Given this list of marker genes BROX, DNAAF10, GLCE, RAB11FIP2, FAM53C, KRTAP4-1, ZNF91, GRK2, NFAT5, PNRC1, NUAK2 (NUAK family kinase 2), ADA2, BHLHE22, FGD6, SCG3, DPY19L3, MEGF9, TMEM214, THEMIS2, CDC42SE1, GLIPR2, CACNA2D2, EBF1, OCM2, CHUK, PIP5K1A, YPEL2, COL6A3 (collagen type VI alpha 3 chain), PAK2, DDX6, SH3BGRL, SPAG9, ISG20L2, E2F5, C22orf46P, BLMH, ZBTB5, ARHGEF40, WDFY3, ALCAM, SEC22B, STRAP, HOXA10, ETNK1, KCNA1, ADARB2, SPO11, KLK10, NUDT5, FBXW7 (NCBI Gene Id 55294), KRT37, FAS, MORN4, EFNA5, TMEM132B, STAC, BLZF1, ZNF583, CBLN2, ZBTB20, C9orf43, UBE2G1, IL1RAP, ZKSCAN2, ASCC1, OCM, NFIB, ALS2, TUBGCP5, CDKN1B, MBP, FBXW2, KAT6B, ZKSCAN4, here is a description of the gene set: studied in species Homo sapiens Genes predicted to be targets of miRBase v22 microRNA hsa-miR-6866-5p in miRDB v6.0 with MirTarget v4 prediction scores > 80 (high confidence targets). from publication Chen Y, Wang X (PMID 31504780) Human Gene Set: MIR6866_5P